The following is a description of a gene set: The reciprocal chromosomal translocation t(4;11) is correlated with infant, childhood, adult and therapy-related high-risk acute leukemia. Here, we investigated the biological effects of MLL.AF4, AF4.MLL or the combination of both reciprocal fusion proteins in a conditional in vitro cell culture model system. Several parameters like cell growth, cell cycling capacity, apoptotic behavior and growth transformation were investigated under physiological and stress conditions. Co-transfected cells displayed the highest resistance against apoptotic triggers, cell cycling capacity and loss-of-contact inhibition. These analyses were complemented by gene expression profiling experiments and specific gene signatures were established for each of the three cell lines. Interestingly, co-transfected cells strongly upregulate the homeobox gene Nanog. In combination with Oct4, the Nanog homeoprotein is steering maintenance of pluripotency and self-renewal in embryonic stem cells. Transcription of Nanog and other stem cell factors, like Oct4 and Bmi1, was verified in biopsy material of t(4;11) patient cells which express both reciprocal t(4;11) fusion genes. In conclusion, the presence of both reciprocal MLL fusion proteins confers biological properties known from t(4;11) leukemia, suggesting that each of the two fusion proteins contribute specific properties and, in combination, also synergistic effects to the leukemic phenotype. studied in species Mus musculus Down-regulated genes from the set E (Fig. 5a): specific signature shared by cells expressing either MLL-AF4 or AF4-MLL fusion proteins alone, and those expressing both fusion proteins. Mouse Gene Set: GAUSSMANN_MLL_AF4_FUSION_TARGETS_E_DN from publication Gaussmann A, Wenger T, Eberle I, Bursen A, Bracharz S, Herr I, Dingermann T, Marschalek R (PMID 17130830), and this is the list of marker genes: Neo1, Gm5799, Angptl6 (NCBI Gene Id 70726), Mgst1, Sgk3, Armcx4, Trib3, Gpt2, Vldlr, Itm2a, Dach2, Col6a3, Tubb3, Cdsn, Rab3b, Igfbp4, Arxes1, Plagl1, Peg3, Ctla2b, Taf7l, Serpinb9g, Gpnmb, Morc4, Stbd1, Ctla2a, Serpinb9f